The following is a description of a gene set: Any process that modulates the frequency, rate or extent of the directed movement of calcium ions into, out of or within a cell, or between cells, by means of some agent such as a transporter or pore. studied in species Homo sapiens Human Gene Set: GOBP_REGULATION_OF_CALCIUM_ION_TRANSPORT, and this is the list of marker genes: FFAR1, PPP3CC, TRPV3, HOMER3, ADCYAP1R1, P2RX1, TRDN, CACNB4, IL16, CCR1, TRPC3, CACNA1F, GPR35, SPG7, DRD1, TRPV2, APLNR, MIR21, CAV1, CD4, CASK, CCL3, TMC1, TMEM38B, ISL1, CACNG1, SLC30A1, CX3CL1, P2RX5, JPH3, P2RX4, SRI, ATP2B1, BCL2, HOMER1, CAMK2D, PACSIN3, CHD7, DMD, G6PD, FKBP1B, LILRB2, MS4A1, ATP2C2 (ATPase secretory pathway Ca2+ transporting 2), OPRD1, TMEM38A, ITGB3, ORAI1, GSTO1, CASQ2, ADRA2A, SESTD1, NGF, EGF (NCBI Gene Id 1950), SARAF, CACNB3, RYR2, CAV3, KCNN4, WNK3, XCL1, NOS1AP, GRIN3B, PDGFRB, PLPP4, FYN, NOS1, NPSR1, IL13, REM1, AKAP6, BEST1, GRM6, CCL2, CORO1A, PPP3CB, KCNK16, SEMG1, LILRA5, MIR424, PRKCE, TGFB1, TRPC1, PML, MRLN, P2RY6, CRHR1, PTPN6, MIR208B, NTSR1, PPP3R2, NPPA, SLC8A1, FMR1, LYN, DIAPH1, PPP3CA, PDPK1, PRKACA, CALM3, PTK2B, TSPO, STIMATE, CCL5, TRIM27, CXCR3, LILRA2, AFG3L2, CEMIP, EPB41, CACNB2, BAK1, TMC2 (NCBI Gene Id 164301), ASPH, CXCL9, CALCA, PSEN2, MIR34A, MIR1-1, P2RX2, EFHB, ATP1B1, F2, DHRS7C, UBASH3B, UCN, INPP5K, CACNB1, CREB3, CACNA2D1, UBQLN1, LACRT, CACNA1C, CCL4, GNB5, GPER1, GRIN1, SPINK1, YWHAE, STAC, ATP2A1, VMP1, PIK3CG, P2RX7 (purinergic receptor P2X 7), CALM1, VDAC1, LGALS3, SLC8B1, STC2, BAX, HPCA (hippocalcin), STAC3, MIR200C, BIN1, MCUB, CTNNB1, TRPC6, CASR, CYBA (NCBI Gene Id 1535), CACNA1D, CASQ1, JPH2, NOS3, EPPIN, RGS9, CBARP, SPG11, F2RL3, HRC, LPAR3, FCRL3, HOMER2, CAMK2A, CAMK2B, LIME1, SUMO1, SNCA, UCP2, MCHR1, CXCL11, UBR3, HTT, ATG5, GNAI2, GCG, EPO (erythropoietin), MIR133A1, MIR328, MIR93, P2RX3, STRIT1, BDKRB1, GRAMD2A, LILRB1, AKAP5, PDE4B, CLIC2, TMX1, PLCG1, CAMK2G, PDGFB, STAC2, WFS1, FKBP1A, ATP1A2, RGS4, TOR2A, STIM2 (stromal interaction molecule 2), MYLK, SELENON, THY1, HCRT, CRH, METTL21C, JPH4, ANK2, CACNG6, HAP1, JPH1, ABL1, PPP3R1, NIPSNAP2, PDE4D (NCBI Gene Id 654081), CD84, CXCL10, CXCL12, CALM2 (calmodulin 2), CAPN3, SLN, AHNAK, PKD2, APP, PLA2G1B, RCVRN, CD19, F2R, TMBIM6, MIR499A, MIR208A, HES1, CRACR2A (calcium release activated channel regulator 2A), PLN, PRNP, TLR9, GSTM2, PRKD1, TSPAN13, STC1, ADORA2A, STIM1